The following is a description of a gene set: Any process that modulates the frequency, rate or extent of protein glycosylation. Protein glycosylation is the addition of a carbohydrate or carbohydrate derivative unit to a protein amino acid, e.g. the addition of glycan chains to proteins. Mouse Gene Set: GOBP_REGULATION_OF_PROTEIN_GLYCOSYLATION species: Mus musculus, and this is the list of marker genes: Pomt1, Fktn, Ramp1, Abca2, Mgat4d, Ccdc134, Slc51b, Chp1, Golga2, Acer2, Il15, Oga, Pomt2